Given this list of marker genes CSRP3, GNAT1, SLC24A2, PNPLA2, GRIK2, WHRN, MKKS, PJVK, GNAT2, SCN9A, GNAT3, ABCA4, ANO3, PKD1L2, PDZD7, LRIT1, TTN, CHRNA10, CACNA1F, PTPRQ, PIEZO2, BACE1, OPN5, PKD1, COMT, TRPA1, EPHB1, PKD1L3, TRPC3, BEST1, EYS, KCNK2, LXN, TULP1 (NCBI Gene Id 7287), PDE6B, RP1, TNF, OPN1SW, AIPL1, SCN11A, SCN1A, TAC1, GRK4, KCNK4, COL11A1, PRPH2, NMT1, SAG, OPN1MW2, NTSR1, TIMELESS, CAMKMT, PECAM1, RRH, TTR, PKD2L1, CABP4 (calcium binding protein 4), GNAQ, TMEM120A, GJA10, CDS1, PDC, TRPV1, PDE6C, SEMA5B, REEP6, NMT2, ASIC3, TMEM87A, PKD2, GUCY2D, ROM1, NR2E3, STRC, OPN1MW3, FECH, GRM6, CDH2, PIEZO1, TCAP, OPN3, ATP8A2, ADORA1, CXCL12, DISC1, CACNA2D4, ITGA2, PLEKHB1, LHFPL5, WDR47, GRK1, RCVRN, TMC1, ELOVL4, PTK2, HTR2A, PRDM12, CTNNB1, PKD2L2, JUP, GUCA1B, NOX3, PITPNM1, GPR52, CHRNA9, MYC, CNGB1, SCRN3, ADGRV1, CCDC66, GUCY2F, GUCA1ANB-GUCA1A, PCP2, DRGX, OPN4, RHO, HPN, GUCA1A, GNGT2, GNA11, ASIC2, KCNQ1, TMC2, SERPINE2, RGR, REST, RGS9BP, KIT, NTRK1, RPE65, NR2F6, FYN, MMP24, RBP4, OTOP1, TAC4, CACNB4, SLC24A4 (NCBI Gene Id 56796), CRB1, GNGT1, PHF24, OPN1MW, UNC119, PKDREJ, KCNA1, OPN1LW, TACR1, CAV3, CEP250, ANO1, GPR88, PKD1L1, NGFR, NPFFR2, GRK7, here is a description of the gene set: The series of events in which an (non-living) abiotic stimulus is received by a cell and converted into a molecular signal. studied in species Homo sapiens Human Gene Set: GOBP_DETECTION_OF_ABIOTIC_STIMULUS